Given this list of marker genes H2-DMb2, Cd81, Lgals3, H2-DMb1, Havcr2, here is a description of the gene set: Mouse Gene Set: GOBP_REGULATION_OF_T_CELL_ACTIVATION_VIA_T_CELL_RECEPTOR_CONTACT_WITH_ANTIGEN_BOUND_TO_MHC_MOLECULE_ON_ANTIGEN_PRESENTING_CELL Any process that modulates the frequency, rate or extent of T cell activation via T cell receptor contact with antigen bound to MHC molecule on antigen presenting cell. species: Mus musculus